Given this list of marker genes MATN2, PKIA, FAM110C, NAV1, CCL27, EFS, CAMKMT, FBLN5, CDK14, PLSCR1, COL12A1, CRYAB, TAOK3, SMCO4, UNC13D, NID1, NIBAN2, S100A16, STOX2, MVP, GXYLT2, APBB2, CARM1, WIPF1, ZNF423, HS6ST2, KLHL6, KMT2C, PCBD1, FSTL1, CAV2, SPIN1, ZHX3, GMFG, ENOX1, LBH, SARDH, ANGPTL1, VEGFD, RPL22, PLXDC1, RGMA, ADGRE1, LRRC4, TP63, PTPN12, SMIM22, RBP1 (retinol binding protein 1), C1QA, LCP1, DOC2B, TYRO3, NFATC1, DTD1 (NCBI Gene Id 92675), LAPTM5, LYZ, TNFAIP8, CHCHD10, ALDH1B1, BMPER, PTPN1, ETS1, CAVIN3, IARS1, GMPR, ZFP36L1, IL2RG, EYA4, L3MBTL3, PRUNE2, CELF2 (NCBI Gene Id 10659), HMGA2, EMP3, RPL14, NEDD9, MCF2L, HDGFL3, TMCC3, NFIX, ARHGEF25, TGM2, SMAD5, TMSB4X, SORCS2, LITAF, TMEM178B, CLEC7A, RBMS3, RPL22L1, IRAG1, GSN, ART3, CPD, MNDA, SERPINB9, MMP2, RFTN1 (raftlin, lipid raft linker 1), CADM4, LASP1, APOA1, NUAK1, C16orf54, TRPT1, TTC39A, OTUD1, LRIG1, SMTNL2, PAICS, RGS5, CACNA1C, ZG16, SEPTIN11, BMP7, CST12P, EMILIN1, EVA1B, NHSL2, SNX24, GLI1, PLTP, SIPA1L1, FGD1, LRRK1, L3HYPDH, TRIM5, TCF4, SEPTIN4, TMEM204, TGFBI, GSTO1, CAMK2N2, BAG2, TCIM, GNA14, here is a description of the gene set: Genes up-regulated in ovarian tumors from mouse models for the BMP SMAD signaling (gonad specific double knockout of SMAD1 and SMAD5). species: Mus musculus from publication Pangas SA, Li X, Umans L, Zwijsen A, Huylebroeck D, Gutierrez C, Wang D, Martin JF, Jamin SP, Behringer RR, Robertson EJ, Matzuk MM (PMID 17967875) The transforming growth factor beta (TGFbeta) family has critical roles in the regulation of fertility. In addition, the pathogenesis of some human cancers is attributed to misregulation of TGFbeta function and SMAD2 or SMAD4 mutations. There are limited mouse models for the BMP signaling SMADs (BR-SMADs) 1, 5, and 8 because of embryonic lethality and suspected genetic redundancy. Using tissue-specific ablation in mice, we deleted the BR-SMADs from somatic cells of ovaries and testes. Single conditional knockouts for Smad1 or Smad5 or mice homozygous null for Smad8 are viable and fertile. Female double Smad1 Smad5 and triple Smad1 Smad5 Smad8 conditional knockout mice become infertile and develop metastatic granulosa cell tumors. Male double Smad1 Smad5 conditional knockout mice are fertile but demonstrate metastatic testicular tumor development. Microarray analysis indicated significant alterations in expression of genes related to the TGFbeta pathway, as well as genes involved in infertility and extracellular matrix production. These data strongly implicate the BR-SMADs as part of a critical developmental pathway in ovaries and testis that, when disrupted, leads to malignant transformation. Human Gene Set: PANGAS_TUMOR_SUPPRESSION_BY_SMAD1_AND_SMAD5_UP